The following is a description of a gene set: Mouse Gene Set: GOBP_NEGATIVE_REGULATION_OF_CATION_CHANNEL_ACTIVITY Any process that stops, prevents or reduces the frequency, rate or extent of cation channel activity. species: Mus musculus, and this is the list of marker genes: Cbarp, Crbn, Fmr1, Kcnab1, Dysf, Sri, Gstm7, Gnb5, Kcne1, Cacna1f, Ank3, Mmp9, Casq2, Grp, Kcnrg, Gsto1, Epo, Calm3, Calm2, Calm1, Cav1, Drd2, Ubqln1, Drd4, Pkd2, Gpr35, Sumo1, Kcne2, Kcne3, Kcnq1